Given this list of marker genes SLC25A5, SLC29A2, VDAC3, SLC43A3, SLC25A4, SLC29A1, here is a description of the gene set: Human Gene Set: GOBP_ADENINE_TRANSPORT studied in species Homo sapiens The directed movement of adenine, 6-aminopurine, into, out of or within a cell, or between cells, by means of some agent such as a transporter or pore.